Given this list of marker genes LRRTM3, IRF2BPL, CBLN2, FOXJ3, DGKH, ZNF521, VSTM2B, IGLON5 (NCBI Gene Id 402665), LEMD3, HS3ST3A1, DBN1, TMEM150C, MARCHF9, ARCN1, ERC2, SRSF1, NUP42, OLFM3, TOGARAM1, NFIA, NR4A3, PHF13, here is a description of the gene set: studied in species Homo sapiens Genes predicted to be targets of miRBase v22 microRNA hsa-miR-4536-3p in miRDB v6.0 with MirTarget v4 prediction scores > 80 (high confidence targets). from publication Chen Y, Wang X (PMID 31504780) Human Gene Set: MIR4536_3P